The following is a description of a gene set: studied in species Homo sapiens from publication Hebert JD, Myers SA, Naba A, Abbruzzese G, Lamar JM, Carr SA, Hynes RO (PMID 32019869) Human Gene Set: HEBERT_MATRISOME_TNBC_BONE_METASTASIS_TUMOR_CELL_DERIVED We have previously developed methods for enriching tissue samples for their ECM protein content by taking advantage of the relative insolubility of the ECM, and we have used these techniques in conjunction with mass spectrometry-based proteomics to profile the matrisome, the complete collection of both core ECM and ECM-associated proteins, in several different cancers. Here we define and compare the ECM components of metastatic niches and how they differ among the specific secondary sites common in TNBC. For this purpose, we use as a model the MDA-MB-231 human TNBC cell line, originally derived from a patient pleural effusion (24), which is capable of metastasizing to the brain, lungs, liver and bone marrow in mouse xenografts. We identify which ECM proteins are commonly elevated at multiple different metastatic sites, and which are preferentially elevated in particular sites. We investigate how these specific ECM proteins, as well as the tumor matrix overall, are differentially produced by the tumor and stromal cells; in this paper, we use stromal to include all cells in the tumor that are not tumor cells. These comparisons did not simply identify the most elevated proteins in each tissue, but rather the proteins most significantly different in abundance in one tissue relative to all others. Separate analyses were conducted for tumor-cell-derived (human) and stroma-derived (mouse) proteins. In this study, we performed an unbiased, quantitative mass spectrometric survey of ECM proteins present in MDA-MB-231 breast cancer xenograft metastases to the brain, lungs, liver and bone marrow. This gene set lists the tumor-cell secreted matrisome proteins found in significantly higher abundance in TNBC bone metastasis niche compared to TNBC brain, liver and lung metastatic niches. Tumor cell-derived matrisome proteins found in significantly higher abundance in TNBC bone metastasis niche compared to TNBC brain, liver and lung metastatic niches., and this is the list of marker genes: F9, COL2A1, S100A11, COL5A3, S100A6